Given this list of marker genes Atl3, Smpd4, Caml, Tmem38a, Sec31a, Tmem33 (transmembrane protein 33), Zbed3, Use1, Get4, Gramd2a, Tor1aip2, Steep1, Sec16b, Mia3, Polr2m, Reep2, Arl6ip1, Sptssb, Tmem147, Cav2, Mmgt1, Mapk15, Emc10, Pex5, Rab18, Emc2, Tmem170, Ncln, Tmem38b, Esyt3, Dmtn, Wdr83os, Wnk1, Ccdc47, Emc9, Sec61a1, Get1, Cacna1s, Tle6, Retreg2, Rab3gap2, Lrrk2, Htt, Emc8, Atl2, Emc1, Lnpk, Tmco1, Trdn, Bag6, Rtn4, Nomo1, Eif2ak3, Reep5, Vcpip1, Retreg1, Rtn1, Reep3, Get3, Umod, Tram2, Emc3, Bnip1, Rab5if, Retreg3, Myo5a, Zfyve27, Shtn1, Jagn1, Casq1, Emc6, Reep4, Rnf112, Tram1l1, Sgta, Atl1, Rtn2, Lpcat3, Cert1, Tor1b, Rab3gap1 (RAB3 GTPase activating protein subunit 1), Ier3ip1, Emc7, Esyt1, Sec31b, Gak, Tmed2, Esyt2 (NCBI Gene Id 74047), Sec16a, Stx18, Reep1 (receptor accessory protein 1), Vapb, Ubl4a, Vapa, Tram1, Rtn3, Emc4, Rab10, Tmcc1, Lman1, here is a description of the gene set: studied in species Mus musculus Mouse Gene Set: GOBP_ENDOPLASMIC_RETICULUM_ORGANIZATION A process that is carried out at the cellular level which results in the assembly, arrangement of constituent parts, or disassembly of the endoplasmic reticulum.